Given this list of marker genes FZR1, USP5, HMGCS2, DIS3, FAM83H, PRPF8, ADGRG1, NOL7, PPFIA1, SMPD4, NME3, APLP2, CAMSAP2, PTBP1, IL15RA, POLG2, HOXB13, ATP9B, EIF3C, ARPC3, STIL, TNRC6B, MECP2, MOCS3, SELENOT, PBX1, UFL1, MED6, ALKBH6, FSTL3 (follistatin like 3), PDCD4, MTA1, YDJC (YdjC chitooligosaccharide deacetylase homolog), SLC25A11, RAB14, RBCK1, PPAT, TCP1, RGS14, HECTD4, DIMT1, WDR26, KCNE1, MAGOH, SYPL1, LARP1, RAB31, IRF9, PEX11A, PSPH, CCND3, TRIOBP, CHFR, TBCE, SRSF5, LONP1 (lon peptidase 1, mitochondrial), MUS81, EGLN1, SCAMP1, NDC1, CBFA2T2, PRMT1, FUBP1, FECH, CAPN15 (calpain 15), SKP2, DOCK1, CDK2, TFPI, UBE3B, SIVA1, SAPCD2, UBE2G2, KIAA0319L, AIDA, PNPLA4, P2RX4, RPL13, SNHG14, TUBA1A, GPI, MRPS12, TBC1D5, PSME3, AMACR, DLG1, EP400, FAM13A, SRRM1, ERI3, PI4KA, MKNK2, SGPP1, NKX3-1, PSMC3IP, PTGFR, ZNF512B, VEGFA, RAB3D, KCTD15, ETV6, ITPR3, UBA6, PPOX, WBP2, SPG7 (NCBI Gene Id 87549), FLOT2, GRB7, LPCAT3, PRKCH, TBC1D9B, PUDP, HPS1 (NCBI Gene Id 3257), NCOA6, EIF3A, KDM6A, KIF5C, CCNG2 (cyclin G2), PMPCA, TUSC3 (tumor suppressor candidate 3), SLC44A1, STAG2, ITPK1, SERBP1, SMC3, USP34, SOX12, TSC22D3, ANKLE2, NDUFS7, CHKB, ARMH3, GART, DEXI, DDT, MEN1, TRAF4, ATF6, MELTF, CYB5B, ARIH2, MAP3K4, BNIP3, HIPK3, RC3H2, NFIX, PRRG4 (NCBI Gene Id 79056), PUM1, ACY1, MICAL3, KXD1, DAZAP2, VDAC3, SCAMP4, PDLIM5, MVK, TPD52, AP2S1, MAPK9, GEMIN2, LILRB3, VAMP3, GMPR2, MMS19, DHX9, PPP2R2A, AKR7A2, STIP1, ABHD17A, CPT1A, GAA, MED7, PPIL2, BICD2, EPRS1 (glutamyl-prolyl-tRNA synthetase 1), BAG6, SHROOM3, ENO1, AGAP2, TMF1, ST7, ASPH, SURF6, TMX1, SRP72, ELF5, DGKZ, PCGF6, UBE2J1, MAP4, USP21, DYRK3, SSX2IP, FEM1B (NCBI Gene Id 23374), NSUN5, SFRP5, SORBS3, ITGB1BP1, DBI, TMEM259, PPFIBP1, CHAC1, ENPP4, PGGT1B, FAF1, TNFSF13, PLEKHF2, HSPA1A, SNX19, B4GALT6, PKN1, MTMR3, BCLAF1, PRB3, INF2, MAPK14, PAFAH1B1, ZDHHC21, GSE1, ARPC1A, ARFGEF3, DFFA, ABHD14A, RBBP6, GPATCH2, BTG3, FUT11, CARS1, SMARCA2, DECR1, STAU1, RPS6KB2, LIMK2, WDR55, HNRNPU, CEBPD (NCBI Gene Id 1052), RAF1, USP10, AKAP17A (A-kinase anchoring protein 17A), CTDP1, LDHA, GAS8, COX7B, SMYD3, HMGA1, HSPA8, TPP1, ITSN2, RPN1 (ribophorin I), SRF, RBM10, FUT6 (fucosyltransferase 6), TMEM80, CDK16, TRAK1, HDLBP, TMED2 (transmembrane p24 trafficking protein 2), ATP6AP1, RNF41, GTF3C2, AK2 (adenylate kinase 2), MTF2, MTHFD1L, EIF4E2, MAPT, LRP5, GNL3L, DDX11, CUL4B, PRDX3, NOLC1, NME2, SPATS2, EHF, DUS1L, OPA1, RGS2, NUP58, PSMG1, SRSF1, TMEM135, UBE3C, GRN, UROS, PIAS2, RAD1, CUL3, AFG2B, BCL2L2 (BCL2 like 2), CHEK2, CCPG1, PDK1, PPP1R9B (NCBI Gene Id 84687), SMARCD3, CBR1, WSB1, RPS28, MGAT4B, DLAT, TWF1, SLC35F5, SCNN1A, PFKL, RFC3, MSH6, UBE2M, RASSF7, SIN3B, SMARCA4, ZNF654, here is a description of the gene set: Prostate cancer is the most commonly diagnosed noncutaneous neoplasm and second most common cause of cancer-related mortality in western men. To investigate the mechanisms of prostate cancer development and progression, we did expression profiling of human prostate cancer and benign tissues. We show that the SOX4 is overexpressed in prostate tumor samples compared with benign tissues by microarray analysis, real-time PCR, and immunohistochemistry. We also show that SOX4 expression is highly correlated with Gleason score at the mRNA and protein level using tissue microarrays. Genes affected by SOX4 expression were also identified, including BCL10, CSF1, and NcoA4/ARA70. TLE-1 and BBC3/PUMA were identified as direct targets of SOX4. Silencing of SOX4 by small interfering RNA transfection induced apoptosis of prostate cancer cells, suggesting that SOX4 could be a therapeutic target for prostate cancer. Stable transfection of SOX4 into nontransformed prostate cells enabled colony formation in soft agar, suggesting that, in the proper cellular context, SOX4 can be a transforming oncogene. studied in species Homo sapiens Genes down-regulated in LNCaP cells (prostate cancer) by overexpression of SOX4 and up-regulated by its RNAi knockdown. Human Gene Set: LIU_SOX4_TARGETS_DN from publication Liu P, Ramachandran S, Ali Seyed M, Scharer CD, Laycock N, Dalton WB, Williams H, Karanam S, Datta MW, Jaye DL, Moreno CS (PMID 16618720)